Given this list of marker genes GSK3B, NCOA1, EP300, SIRT1, PPP3CB, PRKAB2, PPP3CA, PPARGC1A, UCP2, TFAM, CAMK4, FOXO1, PPP3CC, PPARA, PRKAG3, MEF2A, SIRT3, PRKAB1, PPARGC1B, PRKAA2, PPP3R1 (protein phosphatase 3 regulatory subunit B, alpha), MAPK14, PPRC1, PRMT1, FOXO3, MEF2B, PRKAG2, TFB2M, ESRRA, CAMK2G (calcium/calmodulin dependent protein kinase II gamma), ATF2, MEF2C, MEF2D, BORCS8-MEF2B, PPARG, HDAC1, CREB1 (NCBI Gene Id 1385), GABPA, PPP3R2, PPARD, UCP3, MED1, TFB1M, PRKAA1, MYBBP1A, NRF1, RXRA, PRKAG1, here is a description of the gene set: Energy metabolism Human Gene Set: WP_ENERGY_METABOLISM studied in species Homo sapiens